The following is a description of a gene set: The aggregation, arrangement and bonding together of a set of components to form a postsynaptic density, a region that lies adjacent to the cytoplasmic face of the postsynaptic membrane at excitatory synapse. Mouse Gene Set: GOBP_POSTSYNAPTIC_DENSITY_ASSEMBLY studied in species Mus musculus, and this is the list of marker genes: Pten, Nrxn1 (NCBI Gene Id 68042), Nlgn1, Prickle2, Caskin1 (CASK interacting protein 1), Prickle1, C1ql3, Sipa1l1, Abi3, Csmd2, Lrfn1, Zdhhc12, Ptprs, Cript, Reln, Lats1, Nptx1, C1ql2, Slitrk3, Lrrtm2, Nlgn2, Shank3 (SH3 and multiple ankyrin repeat domains 3), Nrxn2, Lrrc4b, Ntrk3, Fgfr1, Grid2, Ptk2b, Lrrtm1, Ptprd, Abi3bp, Cbln1, Nrxn3, Lrfn4, Il1rap